The following is a description of a gene set: studied in species Homo sapiens Human Gene Set: MIR3162_5P Genes predicted to be targets of miRBase v22 microRNA hsa-miR-3162-5p in miRDB v6.0 with MirTarget v4 prediction scores > 80 (high confidence targets). from publication Chen Y, Wang X (PMID 31504780), and this is the list of marker genes: CYP46A1, LDAH, APOL6, TMEM9, UNC5B, VCPIP1 (NCBI Gene Id 80124), PPM1A, SLFN12, ZNF385B, BACH1, TRIM7, PTER, AGTPBP1, PICALM, POLE3, SPATA31D4, EPG5, DYNAP, CDH23, STK35, ERO1A, EPB41L4B, TPP1, AKTIP, CNOT4, SLC10A7, BRK1, FAM124A, ZNF618, GUCA1B, PARP9 (poly(ADP-ribose) polymerase family member 9), ADGRG5, SEC31B, PCSK1, PRPF40A, CFAP263, COL11A2, CYS1, OSBPL7, C10orf105 (NCBI Gene Id 414152), BCL11A, SMARCA2, DMRTA1, IKZF3, DACT1, GSDMA, SLC25A44, ABCB5, CEP128, RPS6KL1, CLEC4G, CELF4, MMGT1, NRXN1, GABBR2, CDHR1 (cadherin related family member 1), ATF7, URM1, TIPARP, MARCHF6, CCDC127, SEPTIN2, RORA, UQCC6, RPTN, MON1B, YARS1, GKAP1, ZNF35, SGMS1, RPGR, N4BP2L2, LAMTOR4, ARNT, AVPR2, RRH